The following is a description of a gene set: species: Homo sapiens Catalysis of the cleavage of non-standard peptide bonds releasing substituted amino acids such as pyroglutamate or cleave isopeptide bonds, such as many deubiquitinating enzymes. Human Gene Set: GOMF_OMEGA_PEPTIDASE_ACTIVITY, and this is the list of marker genes: APEH (NCBI Gene Id 95915), ASRGL1 (asparaginase and isoaspartyl peptidase 1), GGT5, GGTLC1, PGPEP1, BACE1, GGT3P, GGTLC2, UCHL1, GGT6, TRHDE, GGT7, GGT1, GGTLC3, GGH, GGT2P